The following is a description of a gene set: species: Homo sapiens from publication Chen Y, Wang X (PMID 31504780) Human Gene Set: MIR502_5P Genes predicted to be targets of miRBase v22 microRNA hsa-miR-502-5p in miRDB v6.0 with MirTarget v4 prediction scores > 80 (high confidence targets)., and this is the list of marker genes: C6, MEX3C, ELAVL4, TRIP12, SRPK2, CLSTN2, SERPINI1, B3GNT5, HOXC8, AP2B1, FILIP1L, ADAMTS15, DOT1L, PPM1L, CTLA4, SFMBT2, RAB1B, AGO3, CDKN1B, SYT9, C12orf54, TM2D3, ADAMTS18, GTF2A2 (general transcription factor IIA subunit 2), SAMTOR (NCBI Gene Id 154743), GADD45A, ZNF101, LCA5, NEO1, TAFA1, DAPK1, PABPC1 (poly(A) binding protein cytoplasmic 1), HNRNPA2B1, ARPC1B, QSOX2, ATP1A2, MTARC2, DCAF4L1 (NCBI Gene Id 548643), GABRB2, GPN1, EPHA4, DMRT2, FRMD4A, SLC7A14, MTRF1L, ZNF844, PHF20L1, TXNL4A, SLC35F5, MREG, KLF4, NHLRC1, NDUFV3, COMMD9, BABAM1 (BRISC and BRCA1 A complex member 1), SLC28A3, PLSCR2 (phospholipid scramblase 2), ACO2, ADCY1, ODF4, ARB2A, VSX1, DONSON, PRDM6, FIGN, FYTTD1, OSBPL10, SGIP1, STIMATE, RBAK, PPP4R3B, ZNF471, CELF4, PRLR